Given this list of marker genes PCDHA8, AJUBA, HIRA (histone cell cycle regulator), CNGB1, BBS7, C2CD2, CRLS1, THSD7A, AFDN, OPCML, FOXD4L5, PCDHA13, PSMB1, AMD1, PCDHA4, NRN1, CUL4B, IL17RD, TNFSF8, CPEB2, CUL3, KAT6A, SLC5A7, AFAP1L1, HCFC2, PPP2R2A, ADH4, CHIC1, UBIAD1, CDK12, GORAB, CILK1, GRM4, KIAA1549L, SCOC, PURA, PDE4D, GREB1, RBM20, GLIS2, PTER, KASH5, AMMECR1L, NPTX1, FRMD7, PCDHA2, SERPINF1, XPOT, PCDHA3, SLC4A11, ASS1, NRG3, CDON (NCBI Gene Id 50937), MLLT3, LPP, SLC17A6, DSCAM, UTRN (NCBI Gene Id 7402), TMEM196, AK3, SLC10A3, PLAA, ZNF326, CHCHD3, COPG2, RFT1 (RFT1 homolog), SANBR, TRIM13, SESN3, HOOK1, PCDH17, MALRD1, KLF12, PCDHA10, MIPOL1, TSC22D2, LRRC58, VEPH1, NOG, SAMD13, GRP (gastrin releasing peptide), KCTD18, UNC5D, FUT9 (fucosyltransferase 9), SLC5A12, ZNF710, SWT1, PCDHA9, GPR88, BLOC1S6, LRIG3, MEF2A, NAV2, LRRTM3, PIP5K1B, TMEM132C, ACVR1C, PHC3, PCSK6, FAM120A, KDM7A, CACNG2, NHLRC2, DDX6, CHMP7 (charged multivesicular body protein 7), EHD4, MFSD4B, WDR91, CWC15, THBS1, TPGS2, NIPBL, KCNC2 (NCBI Gene Id 3747), CCND1, CACNA1E, C9orf72, ELOVL7 (ELOVL fatty acid elongase 7), GRAMD1B, FZD2, ANGPT1, TMEM165, POU2F2, MAGI1, CREM, FBXO11, TGFBR3, PDZD2 (PDZ domain containing 2), EIF2B5, ADGRF5, HRH1, CLEC16A, PLEKHA5, RALGPS2, TOM1L1, PHACTR2, ZNF737, LZTFL1, FXR2, PCDHA6, TRIO, CPEB4, PCDHA5, ADAM10, LINC02907, CHL1, TSHR, PDE10A, SLK, LRRC66, STAP1, STX11, YY2, SYAP1, UBE2D2, IRX5, NUDT15, FYN, LAMB4, ZNF385D, CEP350, CSTF3 (NCBI Gene Id 1479), MBNL1, CSGALNACT2, NOVA1, NCSTN, ATG4C, NLGN4X, HOMEZ, MTREX, CFL2, GAS2L3, PLPPR5, MME, CRYBA4, SGMS1, CASK, ZNF99, KDM4B, ZNF80, PDE1C, BACE1, GDAP1L1, CNR1, MAP3K2, HOXC8, FOXO1, CBX6, TLE1, PCDHA1, DCDC2, PI15, SH3KBP1, AUTS2, PCDHA12, SULT1A1, DMRT3, CPEB3, GSK3B, PKP4, PLEKHA3, TFF1, FCRL4, GALNT13, NSL1, PCDHA7, RSBN1 (NCBI Gene Id 54665), RBFOX2, AADAT, TMED7-TICAM2, ONECUT2, C1RL, SLC1A1, MAP3K13, PPARGC1A, ADAMTS3, RORA, C11orf87, SPP1, PAPPA, TRPS1, USP12, GNAO1, SCHIP1, WBP1, TICAM2, NAA50, PGM2L1, PTBP1, TXNDC12 (NCBI Gene Id 51060), ZFX, DNAJC9, SARNP, PCDHAC1, DNAJC14, C6orf132, CD86 (CD86 molecule), SGIP1, DAAM1, PDHA2, KRTAP3-3, TOB2, ANGEL2, NLK, CEP97, PCDHAC2, SYNJ2BP, ARID5B, MBNL3, MAFG, TENT4B, DPH3, STON2, SIK3, SEMA3A, FMN1, PAPOLG, MGAT5, SCRN3, SPATA9, NUPR2, SORT1, ARHGEF26 (Rho guanine nucleotide exchange factor 26), SIX4, ELL, ZNF704, TWIST1, RIMS1, FOXO3, RC3H1, ELOB, ZNF569, CDS1, COL25A1, PI4KA, ZMYND11, ATXN7, STXBP5L, SELENOT, CDK5RAP3, CELF4, CDK6, RAB30, USP9Y, CSRNP3, HIVEP2, RPIA, TNRC6B, TTC19, SLC39A8 (NCBI Gene Id 64116), ASH1L, ABLIM1 (actin binding LIM protein 1), SLC44A5, RNF217, ABCD2, FBXL17 (NCBI Gene Id 64839), GUCY1A2, RB1CC1, PCDHA11, ISM1, MMP13 (NCBI Gene Id 4322, matrix metallopeptidase 13), UGCG, IQCJ-SCHIP1, CACUL1, FGFR2, MSI1, FGF2, CLIC5, FCER1A, GATC, GATA5, UBALD2, THOC2, IKZF1, ACOT8, CES2, IGF1, ACER3, VRK2, SETD9 (NCBI Gene Id 133383), TTR, TAOK1, CCDC125, TMEM41B, CLEC2D, PPP2R5C, TRPC5OS, KIAA1586, LPIN2, DIAPH1, BNC2, METTL14, PLA2G12A, APBB2, DIP2C, ZFAND3, CD2AP, STXBP1, SNX14 (sorting nexin 14), TBC1D8B (NCBI Gene Id 54885), TLCD4, here is a description of the gene set: studied in species Homo sapiens from publication Chen Y, Wang X (PMID 31504780) Human Gene Set: MIR130A_5P Genes predicted to be targets of miRBase v22 microRNA hsa-miR-130a-5p in miRDB v6.0 with MirTarget v4 prediction scores > 80 (high confidence targets).